The following is a description of a gene set: Human Gene Set: GOBP_NEGATIVE_REGULATION_OF_UBIQUITIN_PROTEIN_TRANSFERASE_ACTIVITY Any process that stops, prevents, or reduces the frequency, rate or extent of ubiquitin transferase activity. species: Homo sapiens, and this is the list of marker genes: MAD2L2, MAD2L1, RPL11 (NCBI Gene Id 6135), RPL23, DTX3L, ABL1, FBXO5, CDKN2A, RPL5, USP44, RPS7